The following is a description of a gene set: studied in species Mus musculus Any process that modulates the rate, frequency, or extent of a mRNA catabolic process, the chemical reactions and pathways resulting in the breakdown of RNA, ribonucleic acid, one of the two main type of nucleic acid, consisting of a long, unbranched macromolecule formed from ribonucleotides joined in 3',5'-phosphodiester linkage. Mouse Gene Set: GOBP_REGULATION_OF_MRNA_CATABOLIC_PROCESS, and this is the list of marker genes: Mettl14, Mov10, Pum2, Ythdf1 (YTH N6-methyladenosine RNA binding protein 1), Zfp36, Zar1, Pnpt1, Rbm8a2, Fmr1, Igf2bp3 (NCBI Gene Id 72471), Upf1, Upf3a, Dis3l2, Fxr2, Cnot3, Eif4a3, Ybx1, Tbrg4, Igf2bp2, Csde1, Fus, Vip, Nanos2, Cnot8, Mettl3, Pum1, Nrde2, Hnrnpd, Hnrnpa0, Prr5l, Eif4a3l1, Elavl1, Larp4b, Gigyf2, Fastkd5, Fastkd2, Dcps, Igf2bp1, Caprin1, Senp1, Pabpn1l, Pan2, Btg2, Fastkd3, Mir196b, Carhsp1, Mir196a-2, Rc3h2, Fto, Pkp3, Pcid2, Alkbh5, Nicol1, Rnasel (NCBI Gene Id 353203), Ikbke, Magoh, Taf15, Eif4a3l2, Patl1, Trim71, Pnldc1, Scgb1a1, E2f1, Rc3h1, Pabpc4, Myd88, Zc3h14 (zinc finger CCCH type containing 14), Traf2, Cnot7, Dazl, Nanos3, Rbm33, Tut4, Fastkd1, Pcbp4, A1cf, Dcp1a, Nanos1, Mex3d, Fxr1, Paip1, Tent4b (NCBI Gene Id 70570), Secisbp2, Dnd1, Zc3hav1, Ythdf3, Fam76b, Cacng7, Ttc5, Fastk, Mettl16, Syncrip, Celf1 (NCBI Gene Id 98760), Rock1, Tnrc6b, Tut7, Tent5d, Rida, Mtor, Nbas, Hnrnpc, Patl2, Cirbp, Mir466l, Axin2, Qki, Gtsf1, Polr2g, Samd4b, Tent5b (NCBI Gene Id 242690), Rbm10, Cnot6l, Mir144, Dicer1, Tob1, Piwil4, Srsf1, Dhx9, Gtpbp1, Casc3, Lsm1, Csdc2, Mapkapk2, Ybx2 (Y box protein 2), Mir7578, Thrap3, Cnot6, Tnrc6c, Parn, Apex1 (NCBI Gene Id 11792), Zfp36l1, Rbm46, Vegfa, Brf1, Khsrp, Mir196a-1, Meioc, Tent4a, Zc3h12d, Pde12, Pkp1, Mlh1, Traf5, Zfp36l2, Angel2, Noct, Zfp36l3, Cpeb3, Rock2, Pabpc1, Hnrnpr, Hnrnpu, Pias4, Cnot2, Rbm38, Plekhn1, Ago2, Ptbp1, Piwil1, Rbm8a, Dhx34 (DExH-box helicase 34), Mir451b, Hnf4aos, Hnrnpab, Mir451a, Tnf (tumor necrosis factor), Pan3, Calcr (calcitonin receptor), Tirap, Ago1, Slc11a1, Boll, Apobec1, Rbm47, Samd4, Npm1, Il17a, Vim, Dhx36 (DEAH-box helicase 36), Tnrc6a, Tardbp, Zc3h12a, Ythdf2 (NCBI Gene Id 352969), Gdnf, Ago3, Dcp1b, Arid5a, Cnot1, Piwil2, Elavl4, Tent5a, Dcp2, Tent5c, Rbm24 (NCBI Gene Id 76176), Magohb (NCBI Gene Id 66441), Larp1, Eif4enif1, Traf3ip2